Given this list of marker genes SRD5A2, SRD5A3, SRD5A1, AKR1D1, AKR1C3, here is a description of the gene set: Catalysis of the reaction: an enone + NADPH + H+ = a ketone + NADP+. species: Homo sapiens Human Gene Set: GOMF_ENONE_REDUCTASE_ACTIVITY